Given this list of marker genes VPS41 (NCBI Gene Id 27072), SAMD9, ANKFY1, VPS16, RAB4B, VPS11, VPS18, VPS39, VPS4A, VPS8, VPS33A, RAB14, TGFBRAP1, SPHK1, RUFY1, here is a description of the gene set: The homotypic fusion of endocytic vesicles to form or add to an early endosome. studied in species Homo sapiens Human Gene Set: GOBP_ENDOSOMAL_VESICLE_FUSION